The following is a description of a gene set: Mouse Gene Set: GOBP_MEIOTIC_SISTER_CHROMATID_COHESION species: Mus musculus The cell cycle process in which sister chromatids of a replicated chromosome are joined along the entire length of the chromosome during meiosis., and this is the list of marker genes: Rad51c, Bub1b, Sgo2a, Hormad2, Ppp2r5d, Stag3, Gtf2b, Rec8, Meikin, Hormad1, Sycp3, Ppp2r1a, Ppp2r1b, Ppp2r5c, Bub1, Sgo2b